The following is a description of a gene set: species: Mus musculus The directed orientation of lymphocyte signaling molecules and associated membrane rafts towards a chemokine gradient or a contact point with an appropriate activating cell. Mouse Gene Set: GOBP_ESTABLISHMENT_OF_LYMPHOCYTE_POLARITY, and this is the list of marker genes: Scrib, Traf3ip2, Gsn, Ccr7, Ccl21f, Dock8, Ccl21a, Ccl21d, Myh9, Ccl21b, Ccl19-ps6, Abl1, Ccl19-ps5, Abl2, Ccl19-ps3, Ccl21e, Ccl19-ps4, Ripor2, Dock2, Ccl19-ps1, Ccl19, Cyp26b1, Crtam, Flot2